The following is a description of a gene set: Mouse Gene Set: GOBP_TRANSLATIONAL_TERMINATION The process resulting in the release of a polypeptide chain from the ribosome, usually in response to a termination codon (UAA, UAG, or UGA in the universal genetic code). studied in species Mus musculus, and this is the list of marker genes: Jmjd4, Eif5a2, Abce1, Upf1, Mrpl58, Gspt2, Eif5a, Mtrf1, Ogfod1, Etf1, Gspt1, Shfl, Hemk1, Mtrf1l, Mtrfr